Given this list of marker genes Rpa1, Nthl1, Pole, Rfc3, Pole2, Apex1, Lig1, Mpg (N-methylpurine-DNA glycosylase), Adprs, Neil1, Pcna, Rfc1 (NCBI Gene Id 19687), Xrcc1, Neil2, Tdg, Mutyh, Ogg1, Pold4, Mbd4, Pold2, Pold1, here is a description of the gene set: Reactome Pathway: Resolution of Abasic Sites (AP sites) This event has been computationally inferred from an event that has been demonstrated in another species.<p>The inference is based on the homology mapping from PANTHER. Briefly, reactions for which all involved PhysicalEntities (in input, output and catalyst) have a mapped orthologue/paralogue (for complexes at least 75% of components must have a mapping) are inferred to the other species. part of: Base Excision Repair electronically inferred by orthology from the curated human pathway studied in species Mus musculus